Given this list of marker genes SDHD, TK2, SDHB, PRKAR1B, NOTCH3, GRIN2A, HGSNAT, CLN8, GALC, SDHA, PSAP, PAH, MECP2, SDHAF1, CLN5, CLN6, PLEKHG4, GPRC5B, RBM28, FRRS1L, here is a description of the gene set: Human Gene Set: HP_MOTOR_DETERIORATION species: Homo sapiens Loss of previously present motor (i.e., movement) abilities. Motor deterioration